The following is a description of a gene set: species: Homo sapiens The chemical reactions and pathways leading to the formation of tetrapyrroles, natural pigments containing four pyrrole rings joined by one-carbon units linking position 2 of one pyrrole ring to position 5 of the next. Human Gene Set: GOBP_TETRAPYRROLE_BIOSYNTHETIC_PROCESS, and this is the list of marker genes: TSPO, ABCB6, NFE2L1, ALAS2, ATP5IF1, FLVCR1, ALAS1, TMEM14A, SLC25A38, TMEM14DP, TMEM14C, RSAD1, SUCLA2, UROS (uroporphyrinogen III synthase), ABCB7, HMBS, ABCB10, SRRD, COX10, ALAD, SLC25A39, SPTA1, TMEM14EP, IREB2, SLC6A9, SLC11A2, FXN, IBA57, TMEM14B, CPOX, PGRMC1, FECH, UROD, PPOX, COX15